Given this list of marker genes Cmklr1, 4930550C14Rik, Itpr1, Atp2b4, Hnrnpul1, Sult1a1, Duox1 (dual oxidase 1), Arf3, Pdk2, Acad9, Zfp36l1, Ppfia4, Mzf1, Zfp263, Atat1, Wdr41, Lpgat1, Mrpl43, Htr1a, Rasal2, here is a description of the gene set: Genes predicted to be targets of miRBase v22 microRNA mmu_miR_3061_5p in miRDB v6.0 with MirTarget v4 prediction scores > 80 (high confidence targets). Mouse Gene Set: MIR_3061_5P studied in species Mus musculus from publication Chen Y, Wang X (PMID 31504780)